Given this list of marker genes WBP2NL, RAB6B, PARG, SETBP1, IL31RA, BCL2L13, MAP2, BCOR, ATRX, LHFPL5, NFASC, CISD3, SNTB2, NF1, APOH, RAB6D, HNF1B, PSMA4, FUT9, KLF7, ACSM5, ARHGAP1, ZSCAN29, CREBRF, PAPPA, STPG4, PPM1D (NCBI Gene Id 8493), CA3, SLC13A5 (NCBI Gene Id 284111), CTNND2, GPD1L, BMP4, TRO, ZNF135, GRIP2, UBL3, SLC16A2, CTBP1, CADPS, PNMA1, PDE4D, PTPRB, GPR107, SACM1L, GRID1, PLXNA2 (NCBI Gene Id 80253), ANKRD13C, CYP2S1, ALDH9A1, PCMT1, HSDL2, ACLY, GNAT1 (NCBI Gene Id 2779), FOXP3, LINC03042, KIAA1549L, DLAT, RGR, FAM110B, ZNF189, TMEM254, ELAVL1, CDK1, CST9L, MNT, MS4A2, SPATS2 (NCBI Gene Id 65244), P2RY2, QKI, LILRA1, MEIS2, SYT13, ZEB2, ZNF689, NFKBIA, ZBTB8OS, TMLHE, ST8SIA4, GALK2, NR3C1, SSR1, HSPA8, KCNJ3, ZNF74, P2RY10, PAIP2, APP, PCP4, OXSR1, ANK3, FDFT1, here is a description of the gene set: from publication Chen Y, Wang X (PMID 31504780) Human Gene Set: MIR3911 species: Homo sapiens Genes predicted to be targets of miRBase v22 microRNA hsa-miR-3911 in miRDB v6.0 with MirTarget v4 prediction scores > 80 (high confidence targets).